The following is a description of a gene set: species: Homo sapiens Genes down-regulated in SH-SY5Y cells (neuroblastoma) after treatment with epoxomicin, a protease inhibitor causing apoptosis. from publication Concannon CG, Koehler BF, Reimertz C, Murphy BM, Bonner C, Thurow N, Ward MW, Villunger A, Strasser A, Kögel D, Prehn JH (PMID 16983338) Human Gene Set: CONCANNON_APOPTOSIS_BY_EPOXOMICIN_DN The proteasome has emerged as a novel target for antineoplastic treatment of hematological malignancies and solid tumors, including those of the central nervous system. To identify cell death pathways activated in response to inhibition of the proteasome system in cancer cells, we treated human SH-SY5Y neuroblastoma cells with the selective proteasome inhibitor (PI) epoxomicin (Epoxo). Prolonged exposure to Epoxo was associated with increased levels of poly-ubiquitinylated proteins and p53, release of cytochrome c from the mitochondria, and activation of caspases. Analysis of global gene expression using high-density oligonucleotide microarrays revealed that Epoxo triggered transcriptional activation of the two Bcl-2-homology domain-3-only (BH3-only) genes p53 upregulated modulator of apoptosis (PUMA) and Bim. Subsequent studies in PUMA- and Bim-deficient cells indicated that Epoxo-induced caspase activation and apoptosis was predominantly PUMA-dependent. Further characterization of the transcriptional response to Epoxo in HCT116 human colon cancer cells demonstrated that PUMA induction was p53-dependent; with deficiency in either p53 or PUMA significantly protected HCT116 cells against Epoxo-induced apoptosis. Our data suggest that p53 activation and the transcriptional induction of its target gene PUMA play an important role in the sensitivity of cancer cells to apoptosis induced by proteasome inhibition, and imply that antineoplastic therapies with PIs might be especially useful in cancers with functional p53., and this is the list of marker genes: CADPS, SMAD6, AK4, PDK1, NDUFB1, PDGFRL, PLPPR4, NME4, CDC20, TMX4, TOP2A, FZD2, ABCA12, LMO3, ADCY1, PFKP, SNRPG, CADM1, LINC00847, MYB, HMGN3, CLCN4, VCAN, MLLT3, HMGB2, SCHIP1, SIX3, LUM, TFRC, LSM7, UBE2C, BCKDHB, TENM4, MXI1, VSNL1, GNG11, NFIB, MAD2L1 (NCBI Gene Id 4085), LSM2, AGPAT1, GM2A, SLC18A1, CMC4, CETN3, LINC02802, MYC, GDF11, PCOLCE, MYCN, SPC25, CENPA, DHFR, TNFAIP6, DOK4, AKAP1, PDGFRA, C10orf95-AS1, ETV1, RTL8C, IL7, SPTSSA, CBX5, MIR124-1HG, HMMR, NDUFA2, AURKA, TSPOAP1, BIRC5, NREP, MYOF, NHP2, POLR2L, PCLAF, RTN1, DUSP7, ABHD14A, RPS6KA2, CD24, CCNA2, KCNMA1, S100A4, PPFIA4, PTX3, ACYP1, RLN2, NELL1, CHGA, COX17 (cytochrome c oxidase copper chaperone COX17), CDH11, TMSB15A, MARCKSL1 (MARCKS like 1), STMN1, CDK1, CXCR4, H2AZ2, MAP2K6, ESPL1, TMT1A, RPA3, AURKB, ENSG00000291006, LIMK2, LDOC1, SLC6A2, TRAPPC6A, CYB5A, MTUS1, POLD1, DACH1, PHOX2B, FABP5, DBI, DLGAP5, RGS4, ADM, SPRY2, H4C3, PTTG1, NDUFB6, CHRDL1, IGSF3, ALDH7A1, LRRN3, C7, EID1, ICA1, ANAPC15, H4C12, PLK1, ALDOC, KIF23, RGS13, GTF2H5, TFAP2B (transcription factor AP-2 beta), DHCR24, APRT, HDAC9, MFAP4, LDHA, DPY19L1, MARCKS, LMO1, DNPH1, LAGE3, PPEF1, EMILIN1, PEBP1, TMEM158, SORL1, CHRNA3, ELMO1, MFSD10, TWIST1, KIFC1, BUB1, SLC1A1, ATP5MC1, EXOSC9, H4C9, BCL11A, HMGN2P9, MAB21L1, NUDT1, MKI67 (marker of proliferation Ki-67), RPH3A, H1-10, TMSB4X, INSIG1, HK2, ASCL1, TBC1D30, DNASE1L1, RAPGEF4, MAOA, ESRRG, NFE2L3, TMSB10